Given this list of marker genes GLYCTK, KHK, ALDH1A1, TKFC, ALDOB, here is a description of the gene set: species: Homo sapiens Human Gene Set: REACTOME_FRUCTOSE_CATABOLISM Fructose catabolism